The following is a description of a gene set: A disordered proliferation of mature tissues that is native to the site of origin, e.g., exostoses, nevi and soft tissue hamartomas. Although most hamartomas are benign, some histologic subtypes, e.g., neuromuscular hamartoma, may proliferate aggressively such as mesenchymal cystic hamartoma, Sclerosing epithelial hamartoma, Sclerosing metanephric hamartoma. species: Homo sapiens Hamartoma Human Gene Set: HP_HAMARTOMA, and this is the list of marker genes: TMEM231, TCTN3, PTCH1, PIK3CA, SPRED1, DYNC2LI1, NF2, CPLANE1, SMAD4, MAX, TMEM127, MSH6, GLI3, ACVR1, GREM1, KIAA0753, CDC73, SLC25A11, SOX2, PDE6D, PTEN, MSH3, FH, RET, SMO, MVK, DIS3L2, DLST, USF3, KIF7, NF1, TOPORS, TSC2, SDHB, MDH2, NEK9, KRT1, MAN2C1 (NCBI Gene Id 4123), KRT10, BMPR1A, CDKN1B, SDHC (succinate dehydrogenase complex subunit C), FAM149B1, IFNG, TFAP2A, SDHAF2, AKT1, SDHA, SIX6, OFD1, SDHD, TMEM216, STK11, VPS16, KIF1B, ACTB, SEC23B, VHL, APC (APC regulator of WNT signaling pathway), CCND1, FGF3, TSC1, GCDH, TIAM1, KLLN